Given this list of marker genes CALCA, CALCB, RAMP1, CALCRL, CALCR, SCN11A, here is a description of the gene set: Human Gene Set: GOBP_CALCITONIN_GENE_RELATED_PEPTIDE_RECEPTOR_SIGNALING_PATHWAY The series of molecular signals initiated by an extracellular calcitonin gene-related peptide (CGRP) combining with a calcitonin gene-related peptide receptor on the surface of the target cell. Calcitonin gene-related peptide receptors may form dimers, trimers or tetramers. species: Homo sapiens